Given this list of marker genes Pi4ka, Sbf1, Sacm1l, Mtmr2, here is a description of the gene set: electronically inferred by orthology from the curated human pathway Reactome Pathway: Synthesis of PIPs at the ER membrane studied in species Mus musculus part of: PI Metabolism This event has been computationally inferred from an event that has been demonstrated in another species.<p>The inference is based on the homology mapping from PANTHER. Briefly, reactions for which all involved PhysicalEntities (in input, output and catalyst) have a mapped orthologue/paralogue (for complexes at least 75% of components must have a mapping) are inferred to the other species.